The following is a description of a gene set: A protein complex that contains a disulfide-linked heterodimer of T cell receptor (TCR) chains, which are members of the immunoglobulin superfamily, and mediates antigen recognition, ultimately resulting in T cell activation. The TCR heterodimer is associated with the CD3 complex, which consists of the nonpolymorphic polypeptides gamma, delta, epsilon, zeta, and, in some cases, eta (an RNA splice variant of zeta) or Fc epsilon chains. species: Mus musculus Mouse Gene Set: GOCC_T_CELL_RECEPTOR_COMPLEX, and this is the list of marker genes: Trbc2, Trbc1, Trav18, Ptpn6, Trat1, Trac, Trbv19, Cd3d, Cd6, Cd3e, Zap70, Skap1, Ceacam1, Cd3g, Igkc, Ceacam2, Alcam, Cd247, Apbb1ip, Syk